Given this list of marker genes Ank3, Dab1, Cask, Stx2, Kcnq2, Stxbp2, Map4, Epb41l3 (erythrocyte membrane protein band 4.1 like 3), Cav2, Snw1, Gabrg2, Atp2b1, Epb41l1, Clstn1, Cadm1, Gabbr2, Plcb4, Aplp2, Grin1, Epb41, Cdh2, Prkcz, Rap1gap, Grin2b, Camk2g, Cadm3, Efna5, Epb41l2, Mapk4, Clasp1, Kcnma1, Ncdn, Kcnj6 (NCBI Gene Id 547288), Terf2ip, Gphn, Chl1, Agrn, Neo1, Csn3, Ntng1, Grik2, Mapk9, here is a description of the gene set: Mouse Gene Set: WP_SPLICING_FACTOR_NOVA_REGULATED_SYNAPTIC_PROTEINS Splicing factor NOVA regulated synaptic proteins species: Mus musculus